Given this list of marker genes Il27, Il12b, Stat4, P4hb (NCBI Gene Id 18453), Il27ra, Crlf1, Il12a, Tyk2, Ebi3, Il23a, Il23r, here is a description of the gene set: part of: Signaling by Interleukins species: Mus musculus electronically inferred by orthology from the curated human pathway Reactome Pathway: Interleukin-12 family signaling This event has been computationally inferred from an event that has been demonstrated in another species.<p>The inference is based on the homology mapping from PANTHER. Briefly, reactions for which all involved PhysicalEntities (in input, output and catalyst) have a mapped orthologue/paralogue (for complexes at least 75% of components must have a mapping) are inferred to the other species.